The following is a description of a gene set: Human Gene Set: GOBP_AMINO_ACID_CATABOLIC_PROCESS The chemical reactions and pathways resulting in the breakdown of amino acids, organic acids containing one or more amino substituents. species: Homo sapiens, and this is the list of marker genes: DLD, ALDH6A1, ADHFE1 (NCBI Gene Id 137872), GAD1, QDPR (NCBI Gene Id 5860), BCKDHA, MTRR, NOS1, BCKDHB, ENOSF1, CARNS1, KYAT3, HAL, BLMH, ACAT1, HOGA1, HNMT, ASRGL1, ALDH5A1, SDSL, ALDH8A1, IDO2, HIBCH, ACAD8, GLUD2, CSAD, GLS2, KYNU, SARDH, NOS3, THNSL2, GLDC, SLC25A21, MIR21, HSD17B10, PRODH, PPM1K, DBT, GSTZ1, AFMID, IVD, FTCD, ARG2, GCSH, IL4I1, SCLY, BCKDK, BCAT2, CRYM, HDC, PRODH2, SHMT1, KMO, DDO, UROC1, CDO1, ECHS1, GLS, GPT, ETFA, AUH, ARG1, HYKK, GCAT, AADAT, AGXT2, PAH, GAD2, AGXT, OTC (NCBI Gene Id 5009), SLC25A44, GLUL, HGD, RIDA, MAT1A, HMGCLL1, HAAO (NCBI Gene Id 23498), ENSG00000274276, AMT, ACADSB, HIBADH, GPT2, DLST, GOT1 (NCBI Gene Id 2805), PIPOX, CBS, ETFB, NOS2, IDO1, AMDHD1, CARNMT1, ARHGAP11B, ABAT, DDAH1, MCCC1, ACMSD, HPD, FAH, BCAT1, TDO2, ALDH4A1, SDS, MCCC2, HMGCL, AASS, ATP2B4, TAT, KYAT1, OAT, GOT2, GLUD1, DAO